The following is a description of a gene set: Human Gene Set: EHRLICH_ICF_SYNDROM_DN from publication Ehrlich M, Buchanan KL, Tsien F, Jiang G, Sun B, Uicker W, Weemaes CM, Smeets D, Sperling K, Belohradsky BH, Tommerup N, Misek DE, Rouillard JM, Kuick R, Hanash SM (PMID 11741835) ICF (immunodeficiency, centromeric region instability and facial anomalies) is a recessive disease caused by mutations in the DNA methyltransferase 3B gene (DNMT3B). Patients have immunodeficiency, chromosome 1 (Chr1) and Chr16 pericentromeric anomalies in mitogen-stimulated lymphocytes, a small decrease in overall genomic 5-methylcytosine levels and much hypomethylation of Chr1 and Chr16 juxtacentromeric heterochromatin. Microarray expression analysis was done on B-cell lymphoblastoid cell lines (LCLs) from ICF patients with diverse DNMT3B mutations and on control LCLs using oligonucleotide arrays for approximately 5600 different genes, 510 of which showed a lymphoid lineage-restricted expression pattern among several different lineages tested. A set of genes had consistent and significant ICF-specific changes in RNA levels. Half of these genes play a role in immune function. ICF-specific increases in immunoglobulin (Ig) heavy constant mu and delta RNA and cell surface IgM and IgD and decreases in Ig(gamma) and Ig(alpha) RNA and surface IgG and IgA indicate inhibition of the later steps of lymphocyte maturation. ICF-specific increases were seen in RNA for RGS1, a B-cell specific inhibitor of G-protein signaling implicated in negative regulation of B-cell migration, and in RNA for the pro-apoptotic protein kinase C eta gene. ICF-associated decreases were observed in RNAs encoding proteins involved in activation, migration or survival of lymphoid cells, namely, transcription factor negative regulator ID3, the enhancer-binding MEF2C, the iron regulatory transferrin receptor, integrin beta7, the stress protein heme oxygenase and the lymphocyte-specific tumor necrosis factor receptor family members 7 and 17. No differences in promoter methylation were seen between ICF and normal LCLs for three ICF upregulated genes and one downregulated gene by a quantitative methylation assay. Our data suggest that DNMT3B mutations in the ICF syndrome cause lymphogenesis-associated gene dysregulation by indirect effects on gene expression that interfere with normal lymphocyte signaling, maturation and migration. species: Homo sapiens Down-regulated in B lymphocytes from patients with ICF syndrom caused by mutations in DNMT3B compared to normals., and this is the list of marker genes: MEF2C, ZFX, BTN3A2, IGHG1, TRBC2, IGHA1 (immunoglobulin heavy constant alpha 1), UBL5P4, HMOX1, ID3, TNFRSF17, CD27, BTG2, BLK, SLC1A1, ITGB7, INPP4A, TFRC